The following is a description of a gene set: part of: Interleukin-12 family signaling Reactome Pathway: Interleukin-27 signaling Interleukin-27 (IL27) is a heterodimeric cytokine that contains Epstein-Barr virus–induced gene 3 (EBI3) and IL27p28 (IL27). It signals through a receptor composed of Interleukin-6 receptor subunit beta (IL6ST, gp130), which is utilized by many cytokines, and Interleukin-27 receptor subunit alpha (IL27RA, WSX-1, TCCR) (Yoshida & Hunter 2015). species: Homo sapiens, and this is the list of marker genes: STAT1, STAT3, IL27, JAK1, CANX, CRLF1, IL27RA, TYK2, EBI3, JAK2, IL6ST